The following is a description of a gene set: studied in species Homo sapiens Human Gene Set: GOBP_POSITIVE_REGULATION_OF_BICELLULAR_TIGHT_JUNCTION_ASSEMBLY Any process that activates or increases the frequency, rate or extent of tight junction assembly., and this is the list of marker genes: DSG3 (NCBI Gene Id 1830), GDF2, NPHP4, CLDN5, RAC1, IL17A, EPHA2, CLDN1, NPHP1, ACVRL1